The following is a description of a gene set: Human Gene Set: GOBP_STRIATED_MUSCLE_CELL_PROLIFERATION species: Homo sapiens The multiplication or reproduction of striated muscle cells, resulting in the expansion of a cell population. Striated muscles contain fibers that are divided by transverse bands into striations, and cardiac and skeletal muscle are types of striated muscle., and this is the list of marker genes: FOXC2, CDK1, FGF2, CAV2, ARID2, MYH10, FOXC1, TBX5, MYB, MYOG, SELENON, SMAD1, TBX2, SUGT1, EPHB1 (NCBI Gene Id 2047), ZFPM2 (NCBI Gene Id 56958), TGFBR3, PRKAR1A, FES, VGLL4, RUNX1, RBP4, CFLAR, STAT3, NOG, WNT2, NDRG4, BMPR1A, BMP10, KPNA1, MAPK11, MIR17HG, MIR590, TP73, RBPJ, TENM4, SIX5, NRG1, PPARD, MIR204, ABL1, MIR199A1, FOS, PAXBP1, PIM1 (Pim-1 proto-oncogene, serine/threonine kinase), SHH, KCNK2, ANGPT1, NDC80, KRAS, RXRB (NCBI Gene Id 6257), FGF20, SAV1, FGFR2, FGFR1, GLI1, SIX1 (NCBI Gene Id 6495), ERBB4, MIR548C, GATA6, DIPK2A, TGFBR1, MIR19B1, MEF2C, MIR199B, JARID2, MAPK14, JAK2, MIR200B (microRNA 200b), NKX2-5, MEGF10, HGF, MIR873, AKIRIN1, NOTCH1, MIR509-1, YAP1, ANHX, TGFB2, DSN1, FGF9, SKI, MSTN, MIR1-1, HEY2, CCNB1, TBX20 (T-box transcription factor 20), MIR222